Given this list of marker genes AARS1, RBM10, ERGIC1, MYL11, ERCC1, CLTCL1, ZC4H2, PUF60, PHEX, LMNA, MET (MET proto-oncogene, receptor tyrosine kinase), TNNI2, BAP1, ZMPSTE24, OTUD5, NUP188, PLAA, SOX4, MYBPC1, SLC29A3, PEX1, SLC2A10, MAF, POR, ERCC6, FLNA, NDE1, ARID1B, CCDC8, WRN, MUSK, MYH3, NUP88, SCYL2, CHRNG, ADAT3, IPO8, FIG4, CUL7, PHGDH, VAC14, TELO2, RELN, ERCC5, DPH5 (diphthamide biosynthesis 5), EMG1, MAGEL2, TPM2, COASY, NALCN, FILIP1, EXOC7, COL25A1, KATNB1, SAMD9, SMPD4, GLE1, KIF14, RSPRY1, EPB41L1, PSAT1, TOR1A, OBSL1, ERCC2, H4C9, ATPAF2, EN1, HOXD10, FGFR2, TNNT3, DOK7, here is a description of the gene set: An abnormality of the talus. studied in species Homo sapiens Human Gene Set: HP_ABNORMAL_TALUS_MORPHOLOGY Abnormal talus morphology